The following is a description of a gene set: studied in species Mus musculus Mouse Gene Set: GOBP_T_CELL_ACTIVATION_INVOLVED_IN_IMMUNE_RESPONSE The change in morphology and behavior of a mature or immature T cell resulting from exposure to a mitogen, cytokine, chemokine, cellular ligand, or an antigen for which it is specific, leading to the initiation or perpetuation of an immune response., and this is the list of marker genes: Hmgb1, Gm13283, Sema4a, Havcr2, Ifna16, Rps6, Zbtb7b, Il6ra, Icam1, Gm13275, Il23a, Ifna6, Tnfsf4, Il21, Rc3h2, Kmt2a, Cd74, Irf1, H2-DMb2, Plxna1, Nfkbiz, Stx11, Nlrp3, Foxp1, Il4, Tyrobp, Ifnab, Gpr183, Ifna13, Ptger4, Jak3, Itgal, Cd46, Tmem98, Fcer1g, Smad7, Sema6d, Mir301, Irf4, Ifna4, Ifna2, Clec4e, Cd81, Pf4 (platelet factor 4), Ceacam1, Tsc1, Lef1, Itgb6, Ifna14, Ep300, Eif2ak4, Ifna15, Psen2, Ifng, Myb, Mdk, Gm13271, Ripk2, Slfn2, Lgals1, Stat3, Ifnk, Il18r1, Brd4, F2rl1, Tbk1, Gata3, Pck1, Eomes, Malt1, Fgl2, Loxl3, Trp53, Ccr2, Il6, Ifnb1, Il12b, Spn, Psen1, Gm13276, Ifna12, Ccl19, Ifna5, Lgals3, Stat6, Ifna1, Nckap1l, Gadd45g, Ifna9, Pik3r1, Mir873a, Tnfsf18, Clec4d, Il2, Cracr2a, Lcp1, Tbx21, Apbb1ip, Cd69, Il18, Rc3h1, Shb, Ly9, Gm13277, Ifna11, Socs5, Relb, Opa1 (NCBI Gene Id 74143), Mir326, Ifna7, Gm13272, H2-DMb1, Mtor, Bcl3, Ccr7, Zfp35 (zinc finger protein 35), Bcl6, H2-Ea, Rab27a, Rara, Ccr6, Slc11a1, Entpd7, Tgfb1, Atp7a, Il4ra, Prkcz, Nfkbid, H2-M3, Hlx, Slamf6, Rorc, Men1, Ccl20, Brd2, Zc3h12a, Ascl2, Ifne, Foxp3, Anxa1, Ifnz, Itgb8, Stat4, Trem2, Otud5, Rora, Batf, Il27